The following is a description of a gene set: species: Homo sapiens An abnormal increase in the level of lipoprotein cholesterol in the blood. Hyperlipoproteinemia Human Gene Set: HP_HYPERLIPOPROTEINEMIA, and this is the list of marker genes: LIPC, PCSK9, DYRK1B, GHR, GPIHBP1, CELA2A, TMEM199, ABCA2, CETP, CYP7A1, EMD, ALB, APOA2, LIPA, ABCG5, SMPD1, CEP19, SLC25A13, TTPA, ABCG8, SYNE1, SYNE2, CCDC115, LRP6, APOB, SLC7A7 (NCBI Gene Id 9056), LPL, APOA5, LCAT, EPHX2, UBR1, TMEM43, APOE, LMNA, PPP1R17, LDLRAP1, FHL1, APOC2, LDLR, APOC3